Given this list of marker genes COPS5, USP21, SENP8, OTUB1, UCHL3, COPS4, here is a description of the gene set: Human Gene Set: GOMF_DENEDDYLASE_ACTIVITY studied in species Homo sapiens An isopeptidase activity that cleaves NEDD8 from a target protein to which it is conjugated.